Given this list of marker genes SLFN14, NECTIN1, HYDIN, CFAP45, SPRY4, ALX4, KDM1A, NSD1, BRAF, BBS9, ARMC5, FANCM, BMPR1B, RSPH1, CT55, SMO, HPS4, MOV10L1, FANCF, APOLD1, OTX2, DZIP1, ZP1, USP9Y, SLC39A4, WAS, MC2R, SSX1, TTC29, MYH9, CEP19, DIAPH1, SERPINE1 (NCBI Gene Id 5054), GALC, GJB2, TRIM32, MAP3K1, SOX10, LMNA, DBH, XRCC2, HLA-B, TDRD9, FGFR1, HSPG2, CDKN1C, ZFPM2 (NCBI Gene Id 56958), RTN2, C2CD6, CDKN2A, SNRPN, BMP6, ERAL1, QRICH2, AK7, STS, LHCGR, MT-TQ, ATP7B, SACS, TERT, FSIP2, SNORD116-1, MIF, CFAP61, CHEK1, TEX14, SOS1, RNU4ATAC, LHB, SLC29A3, FOS, ZSWIM7, SPAG17, SETD2 (SET domain containing 2, histone lysine methyltransferase), HPS6, SYNJ1, POLR1C, MRAS, BUD23, CCDC8, TEX11, DHH, KLHL10, GHR, DNM1L, SEMA3E, NR5A1, WFS1, POF1B, SPINK2, FANCE, RAB3GAP1, RRM2B, MT-TF, ERCC2, TBX3, CYP17A1, ESR1, ELN, CFAP44, FANCG, POLG, POLG2, MAD2L2, GNE, CBX2, CFTR, OCA2, FGA, ITGB6, NBEAL2, POU1F1, STAG3, BCOR, ALG1, HDAC8, DCAF17, DNAH9, CCN2, RAD51C, FANCB, WEE2 (WEE2 oocyte meiosis inhibiting kinase), TRIP13, PATL2, PRORP, PRLR, MT-TL1, SUFU, INVS, PALB2, ZMYND10, SOX9, SNORD115-1, TRANK1, DNAJC6, WT1, SNCA, NRAS, SMAD4, NDNF, MCM9, ARL6, FANCL, NBN, GLI2, NLRP2, VAMP7, KRAS, DNALI1, UBE2T, TAF6, SYCE1, ALG5, NPHP4, BSCL2, SNAP29, DAZ4, PIGA, MT-ATP6, AMHR2, LHX4, CCDC40, ANOS1, GNRH1, BAP1, SOHLH1, DTNBP1, ODAD2, ZP3, F13A1, CASP10, TEKT3 (NCBI Gene Id 64518), CATSPER1, TRAF7, CAVIN1, METTL27, IL17RC, KPNA7, SRA1, MKRN3, MANF, LIPE (NCBI Gene Id 3991), ERCC4, ZMYND15 (zinc finger MYND-type containing 15), SCP2, FANCA, DAZ1, CPE, ARMC12, NF2, TPR, BBS7, CTNNB1, SMARCB1, PMM2, ZFX, MRPS7, FOXJ1, SPACA1, PEX6, PHF6, ACTL9, SYCP3, RCBTB1, ERCC5, REC114, KASH5, CFAP298, BBS5, ANTXR1 (ANTXR cell adhesion molecule 1), BBIP1, TAC3, SKI, SUN5, DNAAF4, HARS2, BMP2, POC1A (NCBI Gene Id 25886), MCFD2, LIG4, BLOC1S5, MPLKIP, HMOX1, CTSH, AHSG, LZTR1, CDKN1A (cyclin dependent kinase inhibitor 1A), ZBTB16 (NCBI Gene Id 8070), RBMY1A1, MT-ND6, SMARCE1, ATP5MK, STK36, AKAP3, IFT172, BMP4, AGK, PEX1, FANCC, RASA2, PADI6, NPAP1, PHKA2, BBS12, CTDP1, PML, DNHD1, RAB3GAP2, MSTO1, MGME1, GTF2I, GCLC, EDNRA, LHX3, BCS1L, PTPRJ (protein tyrosine phosphatase receptor type J), ARL2BP, GGPS1, SLC37A4, PNLDC1, MEIOB (NCBI Gene Id 254528), PCSK1, TAF4B, PSMC3IP, ERCC1 (ERCC excision repair 1, endonuclease non-catalytic subunit), FOXA2, STAT3, ATP5F1E, VCY, MYH3, MT-TW, FCGR2C, DNAH2, CHD7, RARA, SPIDR, DMXL2, CDKN2B, DAZ2, STUB1, TTC21A, HAMP, APC2 (APC regulator of WNT signaling pathway 2), PDHA2, AGPAT2, FSHB, GALK1, TMEM270, VWF, POLE, NUP107, GATA4, PHOX2A, WDR19, SOX3, CACNA1G, KISS1R, CDH23, DIAPH2, PARK7, ERCC3, COL25A1, CHRNG, PTCH2, HSD3B2, SMC3, CYLC1, PROKR2, CISD2, TUBB3, DDB2, B4GALNT1, CCDC146, NEK10, PDPN, ZFP36L2, CHRM3, SLC40A1, FEZF1 (NCBI Gene Id 392779), NIPBL, UCHL1, SLC11A1, MT-CO1, FIP1L1, SLC26A9, FYB1, OBSL1, SLC25A13, RSPH3, GUCY1A1, SAMD9, TACR3, TUBB2B, FLRT3, ATPAF2, MKKS, CEP290, MRE11, TLE6, SYCP2L, CTNS, TRAF3IP2, ODAD1, NR3C1, CFAP410, NTN1, POLR3B, ATM, SEPTIN12, DNAH5, XKRY, NSMF, CHD4, KDM5D, MKS1, WIPF1, BTG4, SOS2, UBE4B, ACR, PROP1, PANX1, MSH5, ITGA2B, MT-ND5, GP1BA, FZD2, FSHR, TERB1, HCRT, PTDSS1, PKD2, BRWD1, GPR161, POLD1, GBA2, ITGB3, SOST, PDE4D, PSMD12, PPARG, RASGRP2, BICC1, NUMA1, DNAAF5, PLAU, CFAP74, DNAAF3, TP63, F11, AARS2, NME5, LUZP1, DMRT1, TYMP, IFT27, ZNRF3, RIT1, RRAS, MYT1L, IL17RD, TP53, CEP112, ESR2, BAZ1B, CFAP65, TRMT10A, COQ2, BBS1, GSTM3, DCTN4, BRCC3 (BRCA1/BRCA2-containing complex subunit 3), AKT2, CYP11A1, PMFBP1 (polyamine modulated factor 1 binding protein 1), LSS, HNF1B, IGF1, DNAH17, SRY, TWNK, KIT, DNAAF11, MT-TS2, IKZF1, ALMS1, GATA3, RPL10L, CFAP43, DNAL4, USP26, FGG, CBL, ITGA8, NDP, CASZ1, C14orf39, REV3L, FANCI, FGFR3, SDCCAG8, CEP164, HROB, POLR3K, GGN, RSPH9, SYCP2, DNAH10, PLAG1 (PLAG1 zinc finger), WWOX, SCLT1, NCF1, BPTF, SLC30A7, RFWD3, PTCH1, CYP19A1, GCM2, TCF12, STAT5B, KCNAB2, FBXO43, M1AP, SRD5A2, CCDC141, ROBO1, MCM3AP, CDC20, DNAL1, MSH4, SEMA3A (NCBI Gene Id 63232), FGF17, DNAJB11, PGR, SPEN, IRF4, ANAPC1, IFT74 (NCBI Gene Id 80173, intraflagellar transport 74), CCDC34, AGGF1, FAS (NCBI Gene Id 355), MAGEL2, FBXO11, BMP15, EIF2S3, CLDN2, CDKN1B, CCNO, CUL4B, RPGR, DHX37, CFAP52, SPRTN, GP1BB, DNAAF1, F13B, PAPSS2, RIN2, THOC6, F2, FANCD2, CNBP, MEI1, OCRL, GP9, PRKAR1A, TPM4, HSD17B3, CHP1, TOP6BL, DNAAF6, OPA1, MDM2, SPEF2, NME8, CFAP70, HSF2BP, PWAR1 (NCBI Gene Id 8122), DNAH11, HESX1, WNT4, NPM1, BRIP1, SPAG1, P2RY11, BRD4 (NCBI Gene Id 90616), CUL7, FKBP6, TTC8, TBL1XR1, PREPL, FGB, PRDM16, ZBTB20, FLI1, TRAF3IP1, DUSP6, SIX6, EIF2B1 (eukaryotic translation initiation factor 2B subunit alpha), USP7, TUBB8, PRKN, HFM1, ZMPSTE24, ATXN8OS, IER3IP1, TFR2, HLA-DRB1, CCDC28B, HERC2, ATP5F1A, CYB5A, HLA-DQA1, MRPS22, PROK2, TXNRD2, IQCB1, TERB2, DMPK (NCBI Gene Id 60405), PPP2R3C, AURKC, APOA1, GDF9, CIDEC, RAD21, PHKB, RAD51, GANAB, PLCZ1, LIG3, PWRN1, BBS2 (NCBI Gene Id 583), BPY2, NR0B1, ACTL7A, ZP2, CCIN, PRKACG, TTC12, CLPP, USP48 (NCBI Gene Id 84845), MT-ND4 (NCBI Gene Id 4538), PIK3CA, AR, RNF212, RFC2, TUBA1A, ATRX, LEP (leptin), LGR4, PHKG2, LEPR, ASTL, CATIP, NIN, FIGLA, NOBOX, CCDC39, TKT, AMACR, ODAD4, HJV, NANOS1, DNAI1, PSMB8, BRCA1, TSGA10, SQSTM1, SLC9A3, STEAP3, FCGR2A, KCNN4, CCDC62, CLCA4, IRF2BP2, PDGFB, SLC26A8, STK33, SLC34A2, HS6ST1, SERPINA1, CDON, ARSL, EIF4H, AMH, AIRE, CEACAM6, BCL10 (NCBI Gene Id 8915), GAS2L2, VPS37D, RERE, ERCC8, LRRC56, EIF2B2, BLM, NNT, EIF2B3, DRC1, PPM1B, DNAJB13, ZPBP, SHOC1, HLA-DQB1, WNT7A, KISS1, ZNF365, TBL2, SLC3A1, ODAD3, PRKCZ, SPRED2, DNAH1, DNAI2, GTF2IRD2, LRRC23 (leucine rich repeat containing 23), BLOC1S3, F10, IQCN, SLC6A14, FASLG, SIL1, GABRD, XPA, DNAAF2, ANK1, POLA1, BRDT, TEX15, CEACAM3, MECP2, CDC14A, RAF1, ARMC2, SIM1, TSPY1, LMNB1, NDN, IL17F, WDR11, ENSG00000288330, DCC, PDE11A, IL17RA, SMC1A, SGPL1, DNAJC30, PEX10, MOS, CAMKMT, RBM28, SCAPER, AKT1, PNPLA6, IFT140, ALG9, GALT (galactose-1-phosphate uridylyltransferase), CCR6, MT-ATP8, F7, POLR3A, NPHP1, MOG, CFAP58, HSD17B4, WDPCP, GCNA, KIF21A, HTT, MEN1, VPS4A, MCIDAS, MCM8, DDX3Y, FMR1, CAV1, BBS10, MT-CO2, AXL, STK11, GNAS, LMAN1, BNC1, CFAP418, HPS5, PLIN1 (perilipin 1), HSFY1, SPATA16, AIP, KCNU1, PHGDH, ERCC6, CFAP47, POR, NHLH2, LAS1L, FGF8, FOXL2, PODXL, VPS13C, CDY1, GNRHR, MRAP, HTRA2, GP6, SPATA22, PKD1, CFAP91, DNAH8, PLXND1, CATSPER2, ABCD1, LIMK1, HFE, CFAP221, EIF2B4 (NCBI Gene Id 8890), YARS1, CDKN2C, TTR, DNAH7, STX1A, LRRK2, TNFSF4, GBA1, WRN, CYP11B1, SMCHD1, MPV17, BRCA2, MNS1, STAR, NPHP3, CFAP251, CDY2A, H6PD, UBAP1, POLR3H, IGF2, ATP5F1D, BBS4, SOX2, MT-TH, CLIP2 (CAP-Gly domain containing linker protein 2), HMGA2, SLC2A3, CLEC7A, DAZ3, PRDM13, NABP1, RPS4Y2, GPR101, CFAP69, XPC, F8, ANAPC7, ADGRG2, RSPH4A, TTI2, F5, PTPN11, OFD1, NLRP5, MT-CO3, DPY19L2, SLX4, MMP23B, GTF2IRD1, RNF216, TGFB1 (transforming growth factor beta 1), LZTFL1, TBL1X, RECQL4, HBB, MAP2K1, CFAP300, PINK1, HEXB, MT-ND1, LARS2, STRC, IRF5, USP8, RRAS2, here is a description of the gene set: Human Gene Set: HP_ABNORMALITY_OF_REPRODUCTIVE_SYSTEM_PHYSIOLOGY Abnormality of reproductive system physiology An abnormal functionality of the genital system. species: Homo sapiens